Given this list of marker genes LAMA5, LAMB3, COL5A2, LAMA1, COL11A1, LAMB2 (laminin subunit beta 2), COL1A1, COL1A2, LAMA2, FN1, COL5A3, LAMC1, LAMA4, COL3A1, COL24A1, LAMC3, LAMA3, VTN, COL27A1, COL2A1, LAMB1, COL11A2 (collagen type XI alpha 2 chain), COL5A1, LAMC2, here is a description of the gene set: Reactome Pathway: Developmental Lineage of Pancreatic Ductal Cells species: Homo sapiens <p>Ductal epithelial cells line the pancreatic ducts in a single layer, changing the shape as ducts increase in size from cuboidal, through low columnar, to high columnar epithelium (Liggitt and Dintzis, “Pancreas”, pp. 241-250). Ductal epithelial cells may have cilia or microvilli on their apical surface (Liggitt and Dintzis, “Pancreas”, pp. 241-250). Besides ductal epithelial cells, main pancreatic ducts sometimes include goblet cells (Liggitt and Dintzis, “Pancreas”, pp. 241-250).</p><p>Ductal epithelial cells develop from bipotent pancreatic trunk progenitor cells, which also give rise to endocrine progenitors and are derived from the primary multipotent pancreatic progenitor cells.</p> part of: Developmental Cell Lineages of the Exocrine Pancreas